Given this list of marker genes ACVR1B, CER1, CRIPTO3, ACVR2A, CRIPTO, LEFTY2, CFC1, NODAL, DAND5, LEFTY1, ACVR1C, ACVR2B, here is a description of the gene set: species: Homo sapiens Regulation of signaling by NODAL Human Gene Set: REACTOME_REGULATION_OF_SIGNALING_BY_NODAL